The following is a description of a gene set: Reactome Pathway: Epigenetic regulation of gene expression by MLL3 and MLL4 complexes The KMT2C (MLL3) complex, together with the related KMT2D (MLL4) complex, is most similar to Drosophila Trr (Trithorax-related) and mediates histone H3 lysine-4 (H3K4 - lysine 5 in nascent histone H3) monomethylation, with the establishment of the H3K4me1 epigenetic marks, at transcription enhancers throughout the human genome (For review, please refer to Hu et al. 2013, Piunti and Shilatifard 2016, Klonou et al. 2021).<br><br>The MLL3 and MLL4 complexes monomethylate H3K4 at transcription enhancers throughout the human genome, with estimates ranging from approximately 12,000 to over 20,000 sites, depending on the cell type and developmental stage. Full activation of gene expression through MLL3 and MLL4 complex target enhancers appears to require simultaneous monomethylation of H3K4 by MLL3 and/or MLL4 complexes, and acetylation of H3K27 by the histone acetyltransferase p300/CBP, recruited to enhancers through direct interactions with the MLL3 and MLL4 complexes. KDM6A (also known as UTX), a lysine demethylase that acts as an accessory subunit of MLL3 and MLL4 complexes, facilitates H3K27 acetylation by removing inhibitory methyl groups from H3K27, deposited by the Polycomb repressor PRC2 complex.<br><br>KMT2C (also known as MLL3), the catalytic subunit of the MLL3 complex, contains two closely related plant homeodomain (PHD) zinc finger clusters, with 6-7 zinc fingers, in the N-terminal region, and a single PHD zinc finger near the C-terminus, which are involved in protein-protein interactions. The HMG domain in KMT2C enables DNA binding, while the SET domain provides catalytic activity. KMT2C possesses multiple nuclear receptor (NR) interaction motifs (LLXXL or LXXLL), which are important for recruitment of the MLL3 complex to NR-regulated enhancers.<br><br>While H3K4 monomethylation by MLL3 and MLL4 complexes may not be essential for expression of developmental genes, it is likely important for fine tuning of transcription levels and timing, both during normal development and in cancer. Although a broad dispersion of cancer mutations in the coding regions of the KMT2C and KMT2D genes, as well as the presence of many truncating mutations, imply a tumor suppressor role, activating mutations in the SET domains have also been reported, suggesting that a tumor suppressive vs. oncogenic role is context-dependent.<br><br>KMT2C is frequently mutated in cancer. KMT2C may be important for driving hormone-stimulated proliferation of breast cancer cells that are ESR1-positive and ERBB2-negative. In mice, simultaneous overexpression of Pik3ca and inactivation of the Kmt2c blocks differentiation of the mammary gland and leads to increased stem cell self-renewal through HIF pathway activation.<br><br>Non-small cell lung cancer (NSCLC) is characterized by frequent co-occurrence of mutations in KMT2C and KMT2D (also known as MLL4, the catalytic subunit of the MLL4 complex).<br><br>DNA damage-induced transcription of TP53 target genes requires both KMT2C and KMT2D. KMT2C is also implicated in TP53-dependent DNA double strand break repair in a transcription-independent manner. KMT2C and KMT2D contribute to maintenance of epithelial cell states by negatively regulating the epithelial-to-mesenchymal transition. KMT2C mutations in lung and breast cancer are frequently found in the first PHD that is involved in the interaction with the BAP1 histone deubiquitinating complex, linked to Polycomb repressor complex-dependent gene silencing.<br><br>Heterozygous germline LOF mutations in KTM2C are associated with Kleefstra syndrome-2 and autism spectrum disorder.<br><br>In mouse, Kmt2c and Kmt2d are implicated in enhancer priming and de novo enhancer activation during embryonic development. This function is not essential for the maintenance of cell identity and self-renewal of embryonic stem cells (ESCs) and somatic cells but is necessary for ESC reprogramming during differentiation and for production of induced pluripotent stem cells (iPSCs).<br><br>Knockout of KMT2D, the catalytic subunit of the MLL4 complex, in human colon carcinoma cell line HCT116, which already harbors inactivating mutations in both alleles of KMT2C (the catalytic subunit of the MLL3 complex), leads to significant global reduction of H3K4 monomethylation. Knockout studies of KMT2C and KMT2D in HCT116 cells and mouse embryonic fibroblasts (MEFs) implicate at least partially redundant roles of MLL3 and MLL4 complexes in H3K4 monomethylation. Genome-wide ChIP-seq analysis in both HCT116 cells and MEFs showed that ~80% of the MLL4 peaks are enriched at intergenic and intragenic regions, while only ~20% of the peaks map to transcription start sites (TSS). MLL4 binding sites at SAE1 and AP3B1 gene loci in HCT116 cells, and at Nanog and Lefty1 loci in MEFs, are co-occupied by enhancer region markers H3K4me1, EP300, and acetylated H3K27. Many of the genes associated with MLL3/MLL4-bound enhancers in HCT116 cells are implicated in intracellular signaling, while genes associated with MLL3/MLL4-independent enhancers tend to be implicated in regulation of gene expression.<br><br>HOXA9, encoded by a target gene of KMT2A (MLL1) and KMT2B (MLL2) complexes, may function as a pioneer factor at de novo enhancers in acute myeloid leukemia (AML) and recruit CEBPA and the MLL3 and MLL4 complexes to enhancers of leukemogenesis-promoting genes.<br><br>KMT2D is frequently mutated in cancer and is one of the most frequently mutated genes in non-Hodgkin lymphoma, such as follicular lymphoma and diffuse large B cell lymphoma, where loss-of-function (LOF) of KMT2D appears to be an early event that cooperates with the over-expression of the BCL2 oncogene. Knockout of Kmt2d in mouse B cell progenitors impairs their differentiation and promotes lymphoma development. KMT2D LOF in lymphoma is associated with reduced H3K4me1 mark at enhancers of multiple tumor suppressor genes.<br><br>KMT2D chromatin enrichment sites significantly overlap with TP53 binding sites. Aberrant transcription associated with TP53 mutations in colon carcinoma is dependent on KMT2D-mediated H3K4 monomethylation. KMT2D can be inactivated through phosphorylation by SGK1, a PI3K effector kinase closely related to AKT1. SGK1 is the estrogen-inducible kinase, whose transcription is collaboratively activated by ESR1 and KMT2D. SGK1-mediated phosphorylation on KMT2D on serine S1331 near the second PHD results in downregulation of H3K4 monomethylation at ESR1-target genes, thus constituting a negative feedback loop.<br><br>Heterozygous germline LOF mutations in KMT2D are associated with Kabuki syndrome. Kabuki syndrome patients have a modestly increased predisposition to cancer, in particular lymphoma, Wilms tumor, hepatoblastoma, synovial sarcoma and neuroblastoma. Mice with brain-specific knockout of Kmt2d (Mll4) develop medulloblastoma that shows hyperactivation of Ras and Notch signaling.<br><br>Based on mouse studies, MLL3 and MLL4 complexes play an important role in adipogenesis and myogenesis. Kmt2c KO mice die around birth with no obvious morphological abnormalities in embryonic development, while Kmt2d KO mice show early embryonic lethality around E9.5. Pups with Kmt2d KO in precursors of brown preadipocytes and skeletal myocytes are obtained at the expected Mendelian ratio but display marked reduction in back muscles and die immediately after birth due to breathing malfunction, also showing a decrease in brown adipose tissue mass. In cultured mouse brown preadipocytes, KO of Kmt2d leads to a moderate differentiation defect along with a transient up-regulation of Kmt2c expression, whereas KO of Kmt2c has no effect on adipogenesis, suggesting a more prominent role of KMT2D in development and a partial compensation of KMT2D loss by KMT2C. KO of Kmt2d 3T3-L1 mouse white preadipocytes inhibits adipogenesis, and Kmt2c and Kmt2d are also required for adipogenesis in mouse embryonic fibroblasts. By ChIP-seq, the average length of Kmt2d binding regions is between 350 and 400 bp, and the binding regions change dramatically from the preadipocytes stage to the onset of adipogenesis, but are then Kmt2d-binding regions were largely non-overlapping between brown adipocytes and skeletal myocytes. studied in species Homo sapiens part of: Epigenetic regulation by WDR5-containing histone modifying complexes, and this is the list of marker genes: H3-3A, MED24, MED30, KMT2C, NR5A2, H2BC1 (H2B clustered histone 1), AGPAT2, H3C15, H2BC9, CDK5, HDAC3, SIRT1, ACSS3, THRSP, MED31, RXRA, MGLL, GPAM, ELOVL5, MED27, PLIN1, PLIN2, ADIPOQ, MED13, MED4, H2BC5, MED16, H2BC17, PAGR1, H2BC26, SCD, PLIN4, ABL1, MED20, H2AC4, PDK4 (NCBI Gene Id 5166), LPIN1 (NCBI Gene Id 23175), CCNC, CREBBP, H2BC14, CD36, H2BC21, MED12, NCOA6, LPL, KDM6A, DPY30, H2BC12L, H2AZ2, ACSL1, FABP4, PNPLA2 (NCBI Gene Id 57104), MED6, NCOA1, ANGPTL4, H2AC14, H2BC3, PPARGC1B, H2AC20, PPARG, NCOR1, H2BC12, SCD5, CEBPA, CDK8, H2BC11, EP300, MED1 (NCBI Gene Id 9327), TBL1XR1, H2BC4 (NCBI Gene Id 8347), GPS2, H2AJ, DGAT2, CIDEC, NCOA2, AJUBA, LIPE, H2AB1, MED14, RB1, KMT2D, PAXIP1, H2BC15, WDR5, MED17, NCOR2 (NCBI Gene Id 9612), H2AC6, NCOA3, PPARGC1A, H2AC18, H2AC7, TBL1X, PHLDA1, H3C1, H2AX, H2BC13, RBBP5 (NCBI Gene Id 5929), MED23, ASH2L, MED7, MED10, PEX11A (peroxisomal biogenesis factor 11 alpha), H4C1